Given this list of marker genes PDCL, HCG4, ARK2N, SERPINA5, IREB2, RPGRIP1 (NCBI Gene Id 57096), RPGRIP1L, DFFB, CYP1A2, COCH, BHMT, EIF2B1, RFXAP, HIPK2, ASTN1, H4C2, ST8SIA4, CST5, HDAC9, AKAP5, WNT1, ZNF154, LCT, TTC9, GCNT2, TBC1D12, DOC2A, PEX12, GPR4, CXCL6, BMPR2, PRORP, CNTF, NELL1, SSX2IP, GABRA6, TCF21, ZFY, NACAD, RAB3A, TPH1, AVL9, PPP6R2, HSF2BP, RFPL1S, SPAG8, TTF1, LRRTM2, TAF4, SLCO2A1, MINAR1, CRISP2 (cysteine rich secretory protein 2), DZIP1, PRM2, SAA4, CBLIF, FRK, TMEM8B, VPS41, DIO1, BNC1, MPHOSPH8, DCC, TRIM9, BAAT, ZNF264, SEC14L2, KRT37, LCAT, SPAM1, MTRF1L (NCBI Gene Id 54516), CUL3, SLITRK2, WIPF1, TNFSF11, CRISP1, IRGC, CHRNA3, HSD17B2, MPPED2, ODF2, TEKT2, TBC1D31, ADGRB3, ART3, KCNH1, MYT1, FOXN2, ABHD5, GRM8, BRDT, CASQ2, TRPC2, C9, MAP3K14, IFNA4, AKR1D1, AP4E1, RBM17, LCMT2, AVPR1A, MLLT3, TNNI2, KALRN, HOXD9, TCF15, ATG4B, SLCO1B1, SMYD2, GPR176, FAM13C, ZNF208 (NCBI Gene Id 7757), NALF2, OPHN1, BMPER, DCAF4, STARD13, ANGPTL7, NMBR, PHTF1, UGT2B4, IL18RAP, PSMD4P1, FSTL4, NPY5R, IL9, SERPINC1, GK2, SCN2A (NCBI Gene Id 94312), RFX1, ATRNL1, SYT11, IFT88, ADAM7, ZNF177, MYH7, DMP1, ORC4, EPHA7, here is a description of the gene set: Human Gene Set: MORF_EPHA7 Neighborhood of EPHA7 studied in species Homo sapiens Neighborhood of EPHA7 EPH receptor A7 in the MORF expression compendium